The following is a description of a gene set: species: Mus musculus Mouse Gene Set: REACTOME_PEXOPHAGY Pexophagy, and this is the list of marker genes: Uba52rt, Pex5, Nbr1, Rps27a, Ubb, Usp30, Ubc, Atm, Map1lc3b, Uba52, Sqstm1